The following is a description of a gene set: Human Gene Set: WP_ALTERNATIVE_PATHWAY_OF_FETAL_ANDROGEN_SYNTHESIS studied in species Homo sapiens Alternative pathway of fetal androgen synthesis, and this is the list of marker genes: CYB5A, CYP17A1, HSD17B3, AKR1C2, POR, HSD17B6, AKR1C4, HSD3B2, CYP11A1, SRD5A2, STAR